The following is a description of a gene set: Human Gene Set: GOBP_DIACYLGLYCEROL_BIOSYNTHETIC_PROCESS species: Homo sapiens The chemical reactions and pathways resulting in the formation of diacylglycerol, a glyceride in which any two of the R groups (positions not specified) are acyl groups while the remaining R group can be either H or an alkyl group., and this is the list of marker genes: GPAM, MOGAT2, AVIL, PLCE1, PLA2G15, DGAT2, PNPLA2, MOGAT1